The following is a description of a gene set: species: Homo sapiens Catalysis of the reaction: 1-phosphatidyl-1D-myo-inositol 3,5-bisphosphate + H2O = 1-phosphatidyl-1D-myo-inositol 5-phosphate + phosphate + 2 H+. Human Gene Set: GOMF_PHOSPHATIDYLINOSITOL_3_5_BISPHOSPHATE_3_PHOSPHATASE_ACTIVITY, and this is the list of marker genes: MTMR6, MTMR4 (myotubularin related protein 4), MTM1, MTMR1, SYNJ2, MTMR2, MTMR8, MTMR14, MTMR7, MTMR3, SYNJ1, PTPRQ